The following is a description of a gene set: Human Gene Set: SESTO_RESPONSE_TO_UV_C6 studied in species Homo sapiens Cluster 6: genes changed in primary keratinocytes by UVB irradiation. UV radiation is the most important environmental skin aggressor, causing cancer and other problems. This paper reports the use of oligonucleotide microarray technology to determine changes in gene expression in human keratinocytes after UVB treatment. Examination of the effects of different doses at different times after irradiation gave a global picture of the keratinocyte response to this type of insult. Five hundred thirty-nine regulated transcripts were found and organized into nine different clusters depending on behavior patterns. Classification of these genes into 23 functional categories revealed that several biological processes are globally affected by UVB. In addition to confirming a majority up-regulation of the transcripts related to the UV-specific inflammatory and stress responses, significant increases were seen in the expression of genes involved in basal transcription, splicing, and translation as well as in the proteasome-mediated degradation category. On the other hand, those transcripts belonging to the metabolism and adhesion categories were strongly downregulated. These results demonstrate the complexity of the transcriptional profile of the UVB response, describe several cellular processes previously not known to be affected by UV irradiation, and serve as a basis for the global characterization of UV-regulated genes and pathways. from publication Sesto A, Navarro M, Burslem F, Jorcano JL (PMID 11867738), and this is the list of marker genes: PYGL, DHCR24, SEPTIN2, ITGB5, ACO2, PTGS1, DUT, GALE (NCBI Gene Id 2582), GADD45A, POLD2, RRAS, RGS2, XRCC6, CKS1B, CYB5A, CD99, MMP9, HMGN2, ARL4A, ACY1, TGFBI, ECH1, JUND, PTGR1, ATXN10, HNRNPA1, COMMD1, RBP1, CELSR2, CALB2, STK25, TPBG, ATF4, ACAT1, SND1 (staphylococcal nuclease and tudor domain containing 1), H1-10, FDPS, TSC22D1, TNC